The following is a description of a gene set: species: Homo sapiens Abnormal fetal gastrointestinal system morphology An anomalous structural finding of the fetal gastrointestinal system. Terms in this subhierarchy are restricted to findings that can only be observed in the prenatal period. Other HPO terms can also be used to describe fetal phenotypes. Human Gene Set: HP_ABNORMAL_FETAL_GASTROINTESTINAL_SYSTEM_MORPHOLOGY, and this is the list of marker genes: ZIC3, ZBTB42, GNB2, FANCB, NUP88, PTH1R, TRIP11, NPC1, KIF26A, LBR, EIF5A, MDFIC, RHD, NPC2, KMT2D, PIGY, ADGRG6, ZNF699 (NCBI Gene Id 374879), HSD17B4